Given this list of marker genes LIPA, ACOX2, PRDX6, LIPC, PLCG2, BAAT, HMGCS1, APOC2, APOC3, PLA2G7, PLA2G2A, ALDH5A1, IGF1, PLA2G5, PLD1, HMGCS2, PAFAH2, SLC27A2, CLPS, PNLIPRP2 (pancreatic lipase related protein 2 (gene/pseudogene)), PNLIP, PLCD1, here is a description of the gene set: Human Gene Set: MODULE_417 species: Homo sapiens Genes in the cancer module 417.